Given this list of marker genes GNB2, GPX4, KDELR1, CLTA, RHEB, ATP6V0C, EEF1D, UBA1, DDOST, TMBIM6, PSMB2, ARF5, RAC1, FASTK, KXD1, ATP6AP1, TRAPPC3, RER1, AP2S1, BANF1, JTB, ATP6V1F, PDAP1, MYL11, BBLN, TECR, CANX (calnexin), WBP2, DRG1, COPE (COPI coat complex subunit epsilon), COX6A1, COX8A, TMEM147, PPP1R7, PSMB4, BCAP31, SRP9, NDUFV1, GLB1, ATP5MF, CYC1, GANAB, DAP, PSMD8, TMED9, MAP2K2, COX6B1, AP2M1, RALY, CSNK2B, SSR4, SSR2, GPAA1, PPP2R1A, COPS5, here is a description of the gene set: studied in species Homo sapiens Neighborhood of GPX4 glutathione peroxidase 4 (phospholipid hydroperoxidase) in the MORF expression compendium Neighborhood of GPX4 Human Gene Set: MORF_GPX4